The following is a description of a gene set: from publication Chen Y, Wang X (PMID 31504780) Genes predicted to be targets of miRBase v22 microRNA hsa-miR-3682-5p in miRDB v6.0 with MirTarget v4 prediction scores > 80 (high confidence targets). Human Gene Set: MIR3682_5P species: Homo sapiens, and this is the list of marker genes: OGT, GOLM2 (NCBI Gene Id 113201), TASOR, FOXRED2 (FAD dependent oxidoreductase domain containing 2), DCAF7, PABIR3 (PABIR family member 3), CDC42SE2, COG6, KCNT2, MFF, DNAAF4, DCAF4L2, DUSP8, AADAT, MTFR1, GABRA4, PWWP2A, HDAC2, MGAT4A, DOCK4, TMEM50B, ESM1, GABPB2, BMPR1B, FEZ2 (fasciculation and elongation protein zeta 2), DZIP1, SERBP1, BTBD3, TRAPPC9, SCN9A, NAB1, EMX2, RIOK2, FSBP, FERMT2, BASP1, APC, FUT9, SYNJ1, GAL3ST1, EXPH5, CHST7, NOL7, STIM2, DNM3, PMAIP1, RPRD1B, MECOM, CLIC5, ARHGEF9, SRP9, DDX43, MOSPD1, ATF6, CYB5B, MDM4, B4GALT6, STXBP5, ZC3HAV1, CREB1, SLC1A2, RUNDC1, MTF2, SCEL, BRWD3, SPIN1, CAMSAP2, USP38, PIAS2, ZNF319, EEA1, CNKSR2 (connector enhancer of kinase suppressor of Ras 2), PIGN, ATP2C1, CIAO2A, DTWD1, FAIM, KANSL2 (KAT8 regulatory NSL complex subunit 2), HNF1B, IMPACT, USP49, PHF6, DDI2, APBB2, UBE2K, RNF43, AKT3, CACNA1B, GCC2, IFT70A, STAG1, NPY1R, HOXB6, LHX9, MBLAC2, HECTD2, PAK5, UBXN4, MAPK1IP1L, PPM1E, CYSLTR1, ZBTB10, TRIM33